Given this list of marker genes 3110045C21Rik, Tchp, Trim9, Adcy8, Mapk4, Thoc1, Sesn2, Afap1l1, Mettl2, Igfbp4, Rprd1a, Hmga2, Cpa1, Tbc1d9, Tc2n, Polr3d, Slc1a4, Rgcc, Srcap, Iffo2, Ildr1, Tnfrsf12a, Cybrd1, Sox17, Ccnd2, Ctrb1 (chymotrypsinogen B1), Zfp119a, Hira, Mmp15, Sox9, Dyrk3, Dync2i2, Sp5, Lpcat4, Agr3, BC018473, Rad51ap1, Krt23, Ttc27, Mutyh, Smyd5, Cd44, Zng1, Ephb2, Cabcoco1, Slc7a5, Snx24, Shmt2, Brd8, Ndc80, Myc, Sorbs2, Vnn1, Ccdc86, Fam20b, Aqp4 (NCBI Gene Id 11829), Mycl, Fgf1, Cenpp, Snw1, Fkbp5, Hunk, Tfip11, Dgkb, Zscan21, Dis3l, Pask, Rnf43, Ephb3, Dmp1, Cdca7, Rnf149, Pole, Psat1, Txnl1, Glmn, 5730480H06Rik, Zfhx3, Mad1l1, Wdr62, Rnf157, Mettl13, Spaca7, Cela3b, Krtap21-1, Atg9b, Ankrd11, Zfp184 (NCBI Gene Id 74994), Myo1b (myosin IB, NCBI Gene Id 98177), Try5, Zfp800, Eif5b, Nfs1, Abce1, Edn1, Ggh, Trit1, Tenm4, Fads3, Prss3b, Pnliprp1, Tpd52l1, Ttbk2, Lrmda, Dctd, Cct4, Paics, Dtl, Prss2, Trib1, Pramel34, Hspbap1, Gulo, 4930503L19Rik (NCBI Gene Id 74795), Epn3, Klhl8, Scgb2b20, 2410006H16Rik, Tnfrsf19, Dclre1b, Hhat, 6430710C18Rik, Mnd1, Prdx2, Cela2a, Wasf3, Piezo1, Aopep, Pla2g2f, Ror2, Dhx30, Phf21b, Cd80, Acp1, Mt4, Zfp850, Carnmt1, Cdk5rap2, Siva1, Mrps14, Cage1, Stoml1, Rassf4, Tmem131l, C920006O11Rik, Plcd3, Pmm1, Gsdma2, Snhg12, Soat1, Neb, Hs3st1, Bcl11a, Sgf29, Tyms, Mri1, Elp1, Cep72, Fgfrl1, Cdc37, Armc9, Gm7444, Hoxa9, Cldn11, Mrpl47, Zfp746, Dnlz, Myl7, Haghl, Tnni1, Adat1, Fzd6, Slfn4, Zfp1, Sytl1, Klk1b4, Lect2, Anapc4, Dcaf4, Mboat1, Rgs12, Nt5c3b, Fbln2, Ercc4, Tbc1d7, Nr2e3, Mthfd1l, Emc8, Tubb2b, Akap13, Pet100, Atg16l2, Ascl2 (NCBI Gene Id 73698), Ninl, Yju2, Atrip, Tiam1, Clasp2, Afg2b, Slc12a2, Hmgcs2, Psrc1, Cited1, Txnrd3, Zfp867, Pogk, Sox4, Dusp4, Shisa2, Rnase1, Prss41, Trmt9b, Tgif2, Pla2g15, Orc5, Axin2, Trmt1, Emp2, Ccdc163, Meg3, Hopx, here is a description of the gene set: studied in species Mus musculus Genes up-regulated after Cre-lox knockout of APC in the small intestine. from publication Sansom OJ, Meniel VS, Muncan V, Phesse TJ, Wilkins JA, Reed KR, Vass JK, Athineos D, Clevers H, Clarke AR (PMID 17377531) The APC gene encodes the adenomatous polyposis coli tumour suppressor protein, germline mutation of which characterizes familial adenomatous polyposis (FAP), an autosomal intestinal cancer syndrome. Inactivation of APC is also recognized as the key early event in the development of sporadic colorectal cancers, and its loss results in constitutive activity of the beta-catenin-Tcf4 transcription complex. The proto-oncogene c-MYC has been identified as a target of the Wnt pathway in colorectal cancer cells in vitro, in normal crypts in vivo and in intestinal epithelial cells acutely transformed on in vivo deletion of the APC gene; however, the significance of this is unclear. Therefore, to elucidate the role Myc has in the intestine after Apc loss, we have simultaneously deleted both Apc and Myc in the adult murine small intestine. Here we show that loss of Myc rescued the phenotypes of perturbed differentiation, migration, proliferation and apoptosis, which occur on deletion of Apc. Remarkably, this rescue occurred in the presence of high levels of nuclear beta-catenin. Array analysis revealed that Myc is required for the majority of Wnt target gene activation following Apc loss. These data establish Myc as the critical mediator of the early stages of neoplasia following Apc loss. Mouse Gene Set: SANSOM_APC_TARGETS